Given this list of marker genes PAX3, SMARCA4, MN1, TRPS1, BICRA, NRCAM, NFIX, SIM1, TFAP2B, MAPK8IP3, NOTCH2, U2AF2 (U2 small nuclear RNA auxiliary factor 2), TAF1, CDH11, IARS2, TAF6, WAC, SETD1B, KCNJ8, CREBBP, FBXO31, CCDC8, B3GAT3, CNOT2, SLC35A2, SMC3, MYCN, ABCC9 (ATP binding cassette subfamily C member 9), RNF125, KDM5C, TRIO, RUSC2, KMT2A, PPP1R21, SPECC1L, BCOR, NSUN2, COL1A2, SLC25A24, MEF2C, DYM, DPF2, KIFBP, LAS1L, EBF3, FBXL4, MAGEL2, CUL7, ARID1A, GPRASP2, DOCK7, GUSB, TBCK, GNS, FHL1, SMARCB1, HECW2, MTHFS, BCAS3, IGF1R, DNMT3A, RBM10, ZFX, MGAT2, OBSL1, TASP1, SPTBN1, DDX59, MAN2B1, SOX4, SMAD4, EXT1, ACER3, DEPDC5, SMARCA2, SMARCE1, HDAC8, SMARCD1, PDCD6IP, CPLX1, CWF19L1, KCNH1, RPS23, SATB1, SHANK3, AUTS2, POLR1A, HMGA2, FUCA1, NIPBL, RET, TBL1XR1, ARID2, ATP6V1B2, FRMD4A, UBR7, PRKG2, LEMD3, MBD5, TP63, KCNK4, ABCA5, TMCO1, CHST3, MAP3K7, NBAS (NBAS subunit of NRZ tethering complex), FREM1, PUF60, AFF4, EP300, SOX6, CHMP1A, JARID2, PHF6, SPEN, SOX11, GNB2, WNT4, ERLIN2, AIFM1, ZSWIM6, SUMF1 (sulfatase modifying factor 1), SMC1A, SLC9A6, ARID1B, CDK13, KNL1, SMARCC2, KMT2C, ASCC3, FOXL2, DENND5A, RHOBTB2, BRD4, CDON, PHIP, TAF4, ANKRD11 (ankyrin repeat domain containing 11), PSMD12, PRR12, DDB1, TUBGCP2, ASXL3, RALGAPA1, SLC6A17, PSMC1 (proteasome 26S subunit, ATPase 1), RPS6KA3, CLCN3, BPTF, VPS13B, KCNN3, RAD21, CHD1 (NCBI Gene Id 1105), IDUA, CTCF, H4C5 (H4 clustered histone 5), here is a description of the gene set: Thick eyebrow Human Gene Set: HP_THICK_EYEBROW species: Homo sapiens Increased density/number and/or increased diameter of eyebrow hairs.